The following is a description of a gene set: studied in species Mus musculus Mouse Gene Set: GOBP_REGULATION_OF_NK_T_CELL_ACTIVATION Any process that modulates the frequency, rate or extent of natural killer T cell activation., and this is the list of marker genes: Il12b, Cd1d1, Zbtb7b, Tyk2, Cd1d2, Jak2, Il23a, Il18, Rasal3, Cd300a, Il12a, Hsph1